Given this list of marker genes NRAS, SEMA4A, TRAF7, PDE11A, KLLN, ARMC5, TMEM127, EPCAM, MSH2, LMNA, DNAJB11, IDH2, CDKN1B, AIP (NCBI Gene Id 9049), SUFU, MSH3, EPAS1, TP53, VHL, CASP10, PMS1, SDHD, POLD1, TSC2, CCND1, SMARCB1, SMARCE1, MAFA, KIF1B, SDHA, DNMT3A, ATM, NF1, KCNJ10 (NCBI Gene Id 3766), CYP11B2, FOXE1 (NCBI Gene Id 7081), SEC23B, KCNE3, FOXI1, GNAS (GNAS complex locus), HABP2, GREM1, SMARCA4, SOX11, NKX2-1, SMO, HRAS, SDHB, BRAF, SMARCD1, PKD2, NR3C1, DPF2 (double PHD fingers 2), ARID1A, SMARCC2, CHEK2, CDC73, APC, DICER1, DLST, IFT140, PKD1, ATRX, SDHAF2, KRAS, PTEN, USF3 (upstream transcription factor family member 3), CDKN2C, PRKAR1A, ZNRF3, MDM2, KCNQ1OT1, SRGAP1, KEAP1, CDKN1A, NF2, KCNQ1, WRN, CDH23, BAP1, SDHC, MSH6, ZFX, ALG5, PRDM10, CACNA1S, MUTYH, POLE, MDH2, ALG9, USP8, TERT, CDKN1C (cyclin dependent kinase inhibitor 1C), PMS2, PDGFB, CLCNKB, KDM1A, BRCA2, CDKN2B, IDH1, SOX4, MEN1, BMPR1A, ARID2, ARID1B, CYP11B1, YY1, GCM2, MAX, BICC1, KCNJ11, MLH1, MINPP1, IFNG, CTNNB1, TSC1 (TSC complex subunit 1), HEPACAM, JAG1, FAS, TGFBR2, CDKN2A, GANAB, SLC25A11, SLC26A4, IGF2, SCN4A, FASLG, PIK3CA, RET, FLCN, USP48, LZTR1, SLC12A3, GPR101, COQ6, AKT1, RPS20, TG, CLCN2, GCGR, CASR, FH, here is a description of the gene set: Human Gene Set: HP_NEOPLASM_OF_THE_ENDOCRINE_SYSTEM species: Homo sapiens Neoplasm of the endocrine system A tumor (abnormal growth of tissue) of the endocrine system.